The following is a description of a gene set: Human Gene Set: GOCC_EUKARYOTIC_TRANSLATION_INITIATION_FACTOR_3_COMPLEX_EIF3M An eukaryotic translation initiation factor 3 complex that contains the PCI-domain protein eIF3m. species: Homo sapiens, and this is the list of marker genes: EIF3M, EIF3A, EIF3F, EIF3I, EIF3H, EIF3D, EIF3B